The following is a description of a gene set: species: Mus musculus Mouse Gene Set: GOBP_SUPEROXIDE_METABOLIC_PROCESS The chemical reactions and pathways involving superoxide, the superoxide anion O2- (superoxide free radical), or any compound containing this species., and this is the list of marker genes: Il18, Tafa4, Prkcd, Duox2 (NCBI Gene Id 279020), Prdx1, Cygb, Apoa4, Syk, Tgfb1, Cd177, Nrros (NCBI Gene Id 224109), Sh3pxd2b, Noxa1, Akt1, Duox1, Edn1, Itgb2, Mt3, Cyb5r4, Noxo1, Sod2, Mapt, Immp2l, Rac2, Gnai2, Ncf2, Agtr1a, Cxcl1, Agt, Egfr, Sod1, Park7, F2rl1, Slc1a1, Acp5, Sod3, Nox3, Cbs, Fpr2, Hvcn1, Gnai3, Nqo1, Nos2, Crp, Nfe2l2, Clec7a, Fancc, Ncf1, Ccs, Pon3, Ncf4, Sh3pxd2a, Itgb2l, Gstp1, Nos3, Naglu, Nox4, Nox1, Gch1, Fbln5, Mpo, Itgam, Mb, Prg3, Elavl1, App, Abcc1, Atp7a, Cyba, Shc1, Cybb (cytochrome b-245, beta polypeptide), Tyrobp, Dhfr (dihydrofolate reductase), Cd36, Prdx2